Given this list of marker genes HOGA1, NT5E, SESN2, SEZ6L, CPLANE1, DUSP4, PDAP1, UBE2M, EPHB4, STK32A, SH3GL3, NKX3-1, RNASE10, ATXN2, CYP4A22, CGRRF1, IFFO2, EZR, NSUN4, DNAH7, TBXT, MARVELD3, AADAT, ROBO2, GFRA3, HSD17B1, TAGLN2, ZNF354B, DNPEP, HARBI1, ST6GALNAC1, KCNE4, ARPIN, CYP2S1 (NCBI Gene Id 29785), WDR59, FAM163A, PXDN, FGL1, CISH, YIF1A, LENG9, CANT1 (calcium activated nucleotidase 1), AURKA, AKR1B15, TOMM22, TAMALIN, ADGRL2, GBA1, PCSK6, SP4, RPS9, ATP5ME, PEAK1, RAMP2, H2BC18, POU5F2, IFRD2, CSN2, STING1, LAMTOR1, CES4A, CCHCR1, GLOD5, JAK1, PRSS42P, KLHDC3, PHEX, HNF4A (NCBI Gene Id 4339), TRAIP, DOCK5, FBXO41, RAPGEF3, ETV4, MANEAL, NECAB1, WIPF2, NVL, PAQR8, RUFY3, ZSWIM8, TGM2, ALOXE3, IL13RA2, NYX, CD200R1, NHLRC3, NDUFAF8, DYNC2H1, PRPF19, ANKEF1, DLST (dihydrolipoamide S-succinyltransferase), NCR1, PDZD11, SUPV3L1, HAPLN1, CX3CL1, HRH4, PPBP, NDFIP1, ARHGAP31, PSD, VLDLR, NPY1R, ALPK3, SNORD123, GFPT2, DYNC1LI1, HNRNPK, CCNYL1, ATP5MF, ANAPC5, BCL2L11, CSF2RA, PDP2, APEX1 (apurinic/apyrimidinic endodeoxyribonuclease 1), A4GALT, AP2A1, AUP1, PLK1, FKBP4, SPAG6, ELAVL4, XIST, RPS6KA2, NSA2, KCNS2, NFASC, SARS2 (seryl-tRNA synthetase 2, mitochondrial), DNAJB12, CWC22, FA2H, TEX13A, CIDEB, PNLIPRP1, EFHD1, CDC45, KCNQ3, SIN3B, TBATA, ARPC2, SLCO5A1 (NCBI Gene Id 81796), GPR22, NDUFV3, CLEC2L, POLDIP3, BMAL2, KIF12, CLIC1 (chloride intracellular channel 1), SLC39A8, LDHB, SPATA17, NINJ1, LYPLA2 (lysophospholipase 2), MTF1, ITGA1, FNDC8, GOT1L1, RAB12 (RAB12, member RAS oncogene family), MARK1, SEC61B, TMEM116, ITCH, KCTD7, ELL3, CYSLTR2, SERINC3, ACD, YJU2, TYROBP, MDM2, IRF2BP1, GRAP2, PHLDA3, OR52A1, TRIM36, G6PC1, AZIN2 (antizyme inhibitor 2), MRPL52, MRGPRG, ZNF490, USP2, SPATA31F1, ZDBF2, AGBL3, PADI3, TAB1, C16orf92, RPS29, FAM53C, GAL3ST4, MAS1, NAPB, CXADR, ADGRF4, RAB5C (NCBI Gene Id 5878), NANOG, OLFML3, NPC2, PASK, MDH2, here is a description of the gene set: Genes up-regulated in monocytes versus classically activated (M1) macrophages. studied in species Homo sapiens Monocytes mature tom acrophages in the presence of the lineage determining cytokine M-CSF. They can be further polarized into M1 or M2 macrophages with distinct functional properties. We used microarrays to detail the global programme of gene expression underlying macrophage maturation and polarization and identified distinct classes of up-regulated genes during this process. Human Gene Set: GSE5099_MONOCYTE_VS_CLASSICAL_M1_MACROPHAGE_UP from publication Martinez FO, Gordon S, Locati M, Mantovani A (PMID 17082649)